Given this list of marker genes ACVR1C, CFC1, CRIPTO3, MAPK1, GDF1, FOXH1, ACVR2B, DRAP1, ACVR2A, LEFTY2, DAND5, NODAL, ACVR1B, FURIN, LEFTY1, FOXO3, SMAD4, CER1, SMAD3, CRIPTO (NCBI Gene Id 6997), SMAD2, MAPK3, PCSK6, here is a description of the gene set: Reactome Pathway: Signaling by NODAL part of: Developmental Biology Signaling by NODAL is essential for patterning of the axes of the embryo and formation of mesoderm and endoderm. The NODAL proprotein is secreted and cleaved extracellularly to yield mature NODAL. Mature NODAL homodimerizes and can also form heterodimers with LEFTY1, LEFTY2, or CERBERUS, which negatively regulate NODAL signaling. NODAL also forms heterodimers with GDF1, which increases NODAL activity. NODAL dimers bind the NODAL receptor comprising a type I Activin receptor (ACVR1B or ACVR1C), a type II Activin receptor (ACVR2A or ACVR2B), and an EGF-CFC coreceptor (CRIPTO or CRYPTIC). After binding NODAL, the type II activin receptor phosphorylates the type I activin receptor which then phosphorylates SMAD2 and SMAD3 (R-SMADs). Phosphorylated SMAD2 and SMAD3 form hetero-oligomeric complexes with SMAD4 (CO-SMAD) and transit from the cytosol to the nucleus. Within the nucleus the SMAD complexes interact with transcription factors such as FOXH1 to activate transcription of target genes. species: Homo sapiens